Given this list of marker genes Fgf8, Wnt4, Gata2, Lhx3, Bmp2, Fgf2, here is a description of the gene set: Mouse Gene Set: GOBP_THYROID_STIMULATING_HORMONE_SECRETING_CELL_DIFFERENTIATION species: Mus musculus The process in which a relatively unspecialized cell acquires specialized structural and/or functional features of a thyroid-stimulating hormone-secreting cell. A thyroid-stimulating hormone-secreting cell is a basophil cell of the anterior pituitary that produces thyroid-stimulating hormone, thyrotrophin.